The following is a description of a gene set: The interleukin-6 (IL6) family of cytokines includes IL6, IL11, IL27, leukemia inhibitory factor (LIF), oncostatin M (OSM), ciliary neurotrophic factor (CNTF), cardiotrophin 1 and 2 (CT-1) and cardiotrophin-like cytokine (CLC). The latest addition to this family is IL31, discovered in 2004. The family is defined largely by the shared use of the common signal transducing receptor Interleukin-6 receptor subunit beta (IL6ST, gp130). The IL31 receptor uniquely does not include this subunit, instead it uses the related IL31RA. The members of the IL6 family share very low sequence homology but are structurally highly related, forming anti-parallel four-helix bundles with a characteristic “up-up-down-down” topology.<br><br>Although each member of the IL6 family signals through a distinct receptor complex, their underlying signaling mechanisms are similar. Assembly of the receptor complex is followed by activation of receptor-associated Janus kinases (JAKs), believed to be constitutively associated with the receptor subunits.Activation of JAKs initiates downstream cytoplasmic signaling cascades that involve recruitment and phosphorylation of transcription factors of the Signal transducer and activator of transcription (STAT) family, which dimerize and translocate to the nucleus where they bind enhancer elements of target genes leading to transcriptional activation (Nakashima & Taga 1998).<br><br>Negative regulators of IL6 signaling include Suppressor of cytokine signals (SOCS) family members and PTPN11 (SHP-2).<br><br>IL6 is a pleiotropic cytokine with roles in processes including immune regulation, hematopoiesis, inflammation, oncogenesis, metabolic control and sleep. <br><br>IL6 and IL11 bind their corresponding specific receptors IL6R and IL11R respectively, resulting in dimeric complexes that subsequently associate with IL6ST, leading to IL6ST homodimer formation (in a hexameric or higher order complex) and signal initiation. IL6R alpha exists in transmembrane and soluble forms. The transmembrane form is mainly expressed by hepatocytes, neutrophils, monocytes/macrophages, and some lymphocytes. Soluble forms of IL6R (sIL6R) are also expressed by these cells. Two major mechanisms for the production of sIL6R have been proposed. Alternative splicing generates a transcript lacking the transmembrane domain by using splicing donor and acceptor sites that flank the transmembrane domain coding region. This also introduces a frameshift leading to the incorporation of 10 additional amino acids at the C terminus of sIL6R.A second mechanism for the generation of sIL6R is the proteolytic cleavage or 'shedding' of membrane-bound IL-6R. Two proteases ADAM10 and ADAM17 are thought to contribute to this. sIL6R can bind IL6 and stimulate cells that express gp130 but not IL6R alpha, a process that is termed trans-signaling. This explains why many cells, including hematopoietic progenitor cells, neuronal cells, endothelial cells, smooth muscle cells, and embryonic stem cells, do not respond to IL6 alone, but show a remarkable response to IL6/sIL6R. It is clear that the trans-signaling pathway is responsible for the pro-inflammatory activities of IL6 whereas the membrane bound receptor governs regenerative and anti-inflammatory IL6 activities<br><br>LIF, CNTF, OSM, CTF1, CRLF1 and CLCF1 signal via IL6ST:LIFR heterodimeric receptor complexes (Taga & Kishimoto 1997, Mousa & Bakhiet 2013). OSM signals via a receptor complex consisting of IL6ST and OSMR. These cytokines play important roles in the regulation of complex cellular processes such as gene activation, proliferation and differentiation. <br><br>Antibodies have been developed to inhibit IL6 activity for the treatment of inflammatory diseases. Reactome Pathway: Interleukin-6 family signaling studied in species Homo sapiens part of: Signaling by Interleukins, and this is the list of marker genes: JAK2, CBL, IL31, IL6ST, IL31RA (interleukin 31 receptor A), CRLF1, STAT3, OSMR, CLCF1, TYK2, IL11, LIFR, JAK1, CTF1, PTPN11, IL6, IL6R, CNTF, CNTFR, OSM, IL11RA, STAT1, SOCS3, LIF